Given this list of marker genes LMNA, PRR14, STX1B, NUP98, TPR, DAG1, FAM111B, NUP205, NUP93, EIF6, LMNB2, NUP153, PCNA, LBR, PIAS1, LMNB1, EBNA1BP2, LMNTD2, HLCS, NARF, NUP107, SP100, ANAPC4, SUV39H1, RNF220, MSX1, LEMD2, CASK, PSIP1, MAPT, ATF4, here is a description of the gene set: studied in species Homo sapiens Human Gene Set: GOCC_NUCLEAR_PERIPHERY The portion of the nuclear lumen proximal to the inner nuclear membrane.